Given this list of marker genes GFOD2, SFXN3, MAGI1, LOX, UBTD1, GEN1, TMPO (thymopoietin), XKRX, RBCK1, KLF12, TRAM1, ZNF827, NEB, UNKL, AQP7, MYMX, RAI14, ZNF135, TNS4, DLEC1, CEP162, STEAP3, KIAA0513, PLTP, MFHAS1, IDO1, FZD7, NLK, LRATD1, NIPA1, ARHGAP36, GPR161, GABPA, RHBDD1, SETD5, EEF2K, FRMD5 (FERM domain containing 5), MTF2 (NCBI Gene Id 22823), ZNF18, MCCC2, RSF1, EXOSC1, KLF13, NCBP3, SH2D5, TCF12, SLC18A2, ZNF546, ZNF536, PIP4K2B, MXD1, EPHX2, SGCZ, SV2C, VSIG10L, RPL28, BCL9, CAMTA1, GRPR (NCBI Gene Id 2925), TMEM72 (NCBI Gene Id 648109), PRSS33, CDCA7L, PIGA, USPL1 (ubiquitin specific peptidase like 1), ANHX, GUCY1A1, POLE4, NTRK2, SH3PXD2A, DTX1, ZMYND19, TLCD2, GHR, UFM1, PPP2R5E, LPCAT3, TNS2 (tensin 2), PTGES3L, FTO, MDM2, TASP1, PCYOX1, SCN8A, HOGA1 (NCBI Gene Id 112817), U2SURP, STK32A, MECP2, HABP2, ESRRA, TOX4, GATA4, ZNF267, NDFIP1, DERL3, UEVLD, FYCO1, GPC6, S100A10, PHF21A, SPRN, TAFA4, RPS6KA4, SRPK1, CUX1, ZNF347, ZC3H7A, STRAP, C1orf21, IL18R1, ITCH, MYOZ2, TENT5C, FOXO3, KREMEN1, FEZF2, MGLL, PDPK1, PCYT1B, CASKIN2, SLC2A10, MAPRE1 (NCBI Gene Id 22919), TMEM231, TNFRSF13B, PRTG, FAM168A, AUTS2, PLXNA2, SLC39A8, ZNF606, ZNF112, KIF3B, CPD, GRAP2, PLEKHA8, KIAA1217, MAPK1, UMPS, SZRD1, SEM1 (NCBI Gene Id 7979), TMEM178B, CCDC126, SPOCK2 (NCBI Gene Id 9806), MSRB3, RUNX2, RRP15, GAREM1, PLG, CASP10, PCDH7, ZNF423, PLCXD1, here is a description of the gene set: Genes predicted to be targets of miRBase v22 microRNA hsa-miR-6728-3p in miRDB v6.0 with MirTarget v4 prediction scores > 80 (high confidence targets). Human Gene Set: MIR6728_3P from publication Chen Y, Wang X (PMID 31504780) species: Homo sapiens